The following is a description of a gene set: Reactome Pathway: Protein methylation electronically inferred by orthology from the curated human pathway studied in species Mus musculus part of: Post-translational protein modification This event has been computationally inferred from an event that has been demonstrated in another species.<p>The inference is based on the homology mapping from PANTHER. Briefly, reactions for which all involved PhysicalEntities (in input, output and catalyst) have a mapped orthologue/paralogue (for complexes at least 75% of components must have a mapping) are inferred to the other species., and this is the list of marker genes: Eef2kmt, Eef1akmt2, Eef1a1, Vcpkmt, Vcp, Rps2, Etfbkmt, Eef1akmt1, Prmt3, Camkmt, Eef2, Calm1